The following is a description of a gene set: Cutaneous photosensitivity studied in species Homo sapiens An increased sensitivity of the skin to light. Photosensitivity may result in a rash upon exposure to the sun (which is known as photodermatosis). Photosensitivity can be diagnosed by phototests in which light is shone on small areas of skin. Human Gene Set: HP_CUTANEOUS_PHOTOSENSITIVITY, and this is the list of marker genes: HERC2 (HECT and RLD domain containing E3 ubiquitin protein ligase 2), C4B (complement C4B (Chido/Rodgers blood group)), KRT10, AARS1, COL7A1, MKRN3, RNF113A, LYST, TP63, ALAS2, CLTRN, UBE2L3, SNORD115-1, MPLKIP, XPC, MVK, ABCB6, ERCC6, NCF4, TLR7, STAT4, IRF5, MVD, IRAK1, FDFT1, CARS1, NPAP1, PPOX, PRICKLE1, SNORD116-1, PEPD, SPP1, HLA-DRB1, CYBB, BANK1, PCNA, ERCC2, IGHG1, SLC17A9, ERCC5, MAGEL2, POLH, DNASE1, JAZF1, PXK, FECH, KRT5, GJA1, RECQL4, UROD (NCBI Gene Id 7389), FCGR3B, CR2, PMVK, SYNGAP1, PWAR1, FCGR2B, DDX6, ERCC4, NHLRC1 (NCBI Gene Id 378884), SCARB2, XRCC4, SAMHD1, IL10, FERMT1, BLM, CARMIL2, GTF2E2, TREX1, UROS, DNA2, RORB, ITGAM, ERCC1, IFIH1, GATA1, BLK, DHCR7, GJB4, ETS1 (NCBI Gene Id 2113), XPA, CYBC1, PWRN1 (Prader-Willi region non-protein coding RNA 1), FCGR2A, NCF2, GTF2H5, KCTD1, KIAA0319L, UVSSA, LIG4, SLC6A19, CYBA, GJB3, TNFAIP3, FDPS, ERCC8, ERCC3, RECQL, CTLA4, EPM2A (EPM2A glucan phosphatase, laforin), ERCC6L2, KRT1, TARS1, C4A (NCBI Gene Id 720), PDCD1, MECP2, TNIP1, KDSR, GPNMB, TNFSF4, CLPX, PTPN22, NCF1, NBN, DDB2, KRT14, CPOX, CSTB